The following is a description of a gene set: Human Gene Set: GNF2_PTX3 Neighborhood of PTX3 Neighborhood of PTX3 pentraxin-related gene, rapidly induced by IL-1 beta in the GNF2 expression compendium studied in species Homo sapiens, and this is the list of marker genes: EFEMP1, PLOD1, LAMC1, PTX3, PTGS1, SERPINH1, PXDN, IL6, THBS2, B4GALT1, LOXL2, SERPINE1, FBN1, COL5A2, FSTL1, COL5A1, GFPT2 (glutamine-fructose-6-phosphate transaminase 2), YIPF5, PLOD2, CCL2, LAMB1, MMP1 (NCBI Gene Id 4312), SRPX, LOX, CXCL1, LRRC17, CDH11, COL1A2, CXCL6, LOXL1, RCN3, FAP, CALU, COL3A1, CCN2, COL1A1